Given this list of marker genes Eef1a1, Tsfm, Gtpbp2, Eef1b2, Efl1, Eef1d, Gfm1, Abtb1, Hbs1l, Eefsec, Eef1g, Eef2, Gtpbp1, Tufm, Eef1a2, Eif5a, Eif5a2, here is a description of the gene set: Mouse Gene Set: GOMF_TRANSLATION_ELONGATION_FACTOR_ACTIVITY studied in species Mus musculus Functions in chain elongation during polypeptide synthesis at the ribosome.